The following is a description of a gene set: Any process that activates or increases the frequency, rate or extent of an organismal process, any of the processes pertinent to the function of an organism above the cellular level; includes the integrated processes of tissues and organs. studied in species Homo sapiens Human Gene Set: GOBP_POSITIVE_REGULATION_OF_MULTICELLULAR_ORGANISMAL_PROCESS, and this is the list of marker genes: IFNL1, F3, ETV4, ICOS, BCL7B, IL4, LRP1, CD81, GPR68, BRMS1L, PARP2, GRM5, NAIP, STAP1, ADGRV1, ADNP, BTNL2, CCL24, BICRAL (BICRA like chromatin remodeling complex associated protein), EDN2 (endothelin 2), RGCC (regulator of cell cycle), HES1, CD101, STAU2, LAPTM5, PDPN, PRDM14, CDON, PLA2R1, AGER, PTPRD, NLRP5, HLA-DQB1, BBS4, MIR142, DHX58, MIR34C, TLR8, GSDMD, MIR195, DIO3, AXIN2, LPAR3, MIR1908, RAB7B, EREG, DMRTA2, PEAR1, KITLG, NFAM1, MIR21, FCGR1BP, FABP4, MTDH, ANXA2, SLC6A3, TCF7L2, MIR17, PRKG2, BECN1, DSCAM, JMJD8, ADORA2B, ADAM10, SART1, CHI3L1, FLRT1, HLA-DRB1, NKX2-2, AMOT, PRG2, RUNX1, AQP1, F2RL1, CD244, IRF1, HLA-DRB5, ZC3H12A, CAPRIN1 (cell cycle associated protein 1), AMIGO2, BCL11A, FCGR2A, DDX1, CHRNB4, ZP3, NOX5, GHRH, MIR499A, DPP4, EPHB2, TRAF2, HMGB1, FOXS1, ACE2 (angiotensin converting enzyme 2), AGPAT2, AGPAT1, KSR2, TLR5, RAB2B, CD24, TBK1, FCHO1, LILRA2, ACVR1, ICOSLG, PLA2G4A, BRD9, GLMN, LPIN1, TAC1, IL36B, F2R, IRGM, CHUK, FZD9, CD2, CRH, AMBRA1, EZH2, GATA4 (NCBI Gene Id 2626), CSF2, GRPR, SMARCE1, CADM1, MIR132, GPAM, HAVCR1, DHX37, GPR65, CDK18, PTK2B, SAP30L, PRL, TACR1, NLRP9 (NLR family pyrin domain containing 9), CCDC88B, TNFSF4 (NCBI Gene Id 7292), MAP3K8, PDCD6, HSP90AA1, GPRC5B, POLR3A, CMA1, SERPINE1, IL20RB, QKI (QKI, KH domain containing RNA binding), TRIM56, SPTBN1, RUFY4, WDR62, GAS6, CD320, AXL, NACA, HIF1A, TRIM65, CCBE1, XCL1 (NCBI Gene Id 92337), ATXN1, ADM, P2RX7, AVPR1A, SMARCD2, SOX4, GH1, CCR2, ITGA5, RUNX3, PKDCC, LRRN1, USP22, FOXA2, IL17F, SLITRK6, TNFSF13B, PAXIP1, GP9, SASH3, NTRK3, BRD4, BCL9L, LTBP3, HMCES, MSH2, ZCCHC3, AGTR2, EIF2AK2, LILRB4, MECP2, KDM2B, HEG1, ACTB, RSAD2, MTOR, CACNB1 (NCBI Gene Id 782), MIR204, ZNF365, FGF10, NCOA2, MIR34A, FCGR3A, PANX1, ANO6, GPRASP3, STOML2, EMILIN1, RUNX2, CD7, TGFBR2, TRAF3 (TNF receptor associated factor 3), HMGA2, PRKCZ, PTPN1, ROCK1, ATP8A2, TOX, GATA2, MIR144, HLA-A, SIN3A, MEFV, FGFR1, CCL5, GPSM3, ANGPT2, ING2, LACC1, VTN, SPTA1, PHB1, MIR519D, NPY2R, TBC1D24, CGAS, CYBA, PANX2, HRC, ENPP7 (NCBI Gene Id 339221), AKAP12, CCR1, OTP, GRP, CACNB2, NLRP3, CD1D, IGFBP2, ELL3, TPM1, LILRB1, STAT3, IFNG, XBP1, CSK, GALR1, SVEP1, JAK1, NOG, CD36, LNCPRESS1, IFIH1, CBLN2, GDI1, LGALS3, GSX2, HLA-DRA, PIM1, FCN1, EDNRB, BAD, ASIC2, TGFB3, SLC7A1, TGFB1, ATP6AP2, RBM19, IL20, ADM5, TLR4, SNW1, TSKU, AP3B1, PLXND1, SMAD3, APP, MC1R, AGRN, CD80, FLT3LG, UCP1, RPL13A, TBX21, CIB1, TLR7, MED1, CFAP20, FH, TLR9, GHRHR, NFATC4, PQBP1, CELA1, CHIA, MIR29A, NLGN1, TWIST1, SPACA3, SULF2, CLSTN2, VIL1, RNF135, RBBP7, IL7R, TESC, RGS14, F7, ITGB1, UNC13B, HLA-DQA2, MACROH2A2, TRPV2, KMT5B, IL1RAPL1, PPARGC1B, PER2, FMR1, NLGN2, EMILIN2, MIR208A, TJP1, RPTOR, SMURF2, TIGIT (T cell immunoreceptor with Ig and ITIM domains), DMRT1, DBH, SIRPG, CLCF1, AKT1, TP73, PLXNB2, ELANE, JAG1, NCOA3, DISC1, CCN1, WNT1, ADRB2, CCL1, FAM83A, MIR1-1 (NCBI Gene Id 406904, microRNA 1-1), HMSD, CST7, MFN2, CEACAM20, ECRG4, SOX10, HTR2A, CD86, EPHB3, HLA-DPA1, CYP27B1, PPP2R3C, PRKCQ, VKORC1, POLR3F, CAMK4, MIR199A1, NUMBL, NAP1L1, NPTN, SNX4, ITGAX, ZNF322, PTPRZ1, AVP, KPNA2, BLOC1S3, LRPAP1, BASP1, HMGB2, FYN, NOS3, LGALS8, ADORA2A, RREB1, FN1, LRRTM2, BLOC1S6, MAP3K13, FCER1G, PTGIS, CLEC5A, PDE4B, MPL, LBP, FFAR4, RIMS2, EGR2, NGF, LTF, TMIGD2, CHD7, ANGPTL3, NOS2, ID2, HK1, BMPR1B, PDPK1, TP53BP1, ATP2B1, NMU, ITPKA, AMIGO3, POU4F1, ATP1A1, METRN, NODAL, VAV1, NKX6-2, TBXAS1, ADIPOR2, THBS2, SLITRK2, PKP1, ALOX5, CD226, PRG3, CYP8B1, AVPR2, SOX6, DRD2, MIR145, MIR342, EMC10, SERP1, FOXD1, CTNNBIP1, SEMA4A, OAS3, JAK2, SOX15, TLE6, RELA, LY9, TGFBR1, NLRP2, RB1, CD74, PAFAH1B1, GREM1, NEURL1, SRF (NCBI Gene Id 6722), PDCL3, SEMA4D, NEFL, TMEM64, CLEC4D, TGM2 (NCBI Gene Id 7052), NCMAP, IL33, DNAJA3, HHLA2, SHH, SMARCA2, MIR222, IL12RB1, PLAC8, IL7, CAMK2D, TGFB2, RGS4, IL1A, ZEB2, SIX4, LCK, YAP1, ENG, IFNGR1, RAPGEF3, ERAP1, ACTA2, ARID4A, ADCY10, PTPN6, POLR3B, TWF1, MAPT, MEF2C, CD4, CASP1, RORA, B4GALT5, HSPD1, AGO2, MTM1, CD40LG, ATP2A1, ECM1, FBN2, MAVS, IFI16, FGF8, TNFSF14, OAS2, CLSTN1, HRG, CASR, DEF8, IGHD, ARMCX5-GPRASP2, ING1, MIR33A, GATM, CTNNB1, NOX1, ADAM7, TNR, BDNF, PLXNC1, CX3CR1 (C-X3-C motif chemokine receptor 1), HAVCR2, ZMIZ1, SULF1, INAVA, BTG1 (BTG anti-proliferation factor 1), PRKDC, ASCL1, AP3D1, PMS2, ADAM12, HSPB6, AGGF1, ADRB3 (NCBI Gene Id 94406), FGF2, FZD4, ETS1, STIM1, FGF18, TSHR, BMPER, KAT2A, IL32, KAT5, AKIRIN2, TPPP, RIGI, CD47, CBLN1, TMF1, CTSC, THBD, CCND1, PDGFB, TACR3, IL1R1, PRAP1, MTNR1B, TBX20, IL15RA, IRAK3, SIRPA, VSIR, PRKAB2, FFAR3, SLC1A1, ARID2, ITGB8, TAPT1, PRKCH, MYMK, HSPB1 (NCBI Gene Id 3315), TERT, DECR1, PKM, HSPA1A, RNF112, SIGLEC16, NPPB, SPN, DCT (dopachrome tautomerase), TRPM4, CAMP, P2RY1, ROBO2, CAMK2B, TNFSF9, G3BP1, HYAL1, NTRK1, DHX36, CCL3, CD40, PPP3CA, HLA-DOA, HGF (NCBI Gene Id 317720), CD70, VEGFB, SOX9, TTPA, GRID2, OGT, AKAP6, EGR1 (early growth response 1), FGF21, SERPINF2, MMP8, CPT2, TGFB1I1, IL17RC, ADGRB3, CD14, PYDC1, ACIN1, OSM (oncostatin M), C3AR1, ETV5, BATF, UAP1, FUT1, SLC39A10, SELP, CBFB, TESPA1, ALPL, ZFPM2, STK25, IRF3, ATRAID, MIR214 (NCBI Gene Id 406996), TYK2, GRB10, ADCYAP1, SMARCD3, ALOX12B (arachidonate 12-lipoxygenase, 12R type), SORL1, DICER1, CFL1, SMAD2, PLA2G3, FAAH, TET1, IL34 (interleukin 34), C5AR1, IL6R, GBP5, RAB8B, PCK1, KIT, TENT5A, KPNA6, FXR2, BCL3, CDH5, DBN1, CD160, CD3E, EDN1, PTGER4, IRF5, GNAS, ISLR2, NLRP12, PLPP6, CDKL5, APOA5, IL13, SLITRK5, XIAP, ABL1, CBLB, IRF7, BCL7C, MIR181B1, USF1, NELL1, F12, TNFSF12, BICRA, PF4, DYNC1H1, CDKL3, ARRDC4, IL2RG, RASSF10, HLA-DMA, TIE1, TLR3, CLEC9A, FZD5, CSF1R, LETMD1, S100A13 (NCBI Gene Id 6284, S100 calcium binding protein A13), SMARCD1, PLCG1, TRADD, BMP10, OPRM1, RELN, RIPK2, IL16, LRRTM1, PROK2, TRIM27, CLEC4E, NLRP10, CAPRIN2, DAB2, CUX2, CYBB, USP50, ANGPT4, NR1H4, GSTO1, ADRB1, GADD45G, NEGR1, SHLD1 (NCBI Gene Id 149840), SMO, MRTFB, MSX2, RAB21 (RAB21, member RAS oncogene family), HLA-E, CHODL, CCR3, EFNB2, OXT, MIR125B1, YBX3, ITK, BTN3A1, CARD11, LHX1, MAP6, NPS, ACTL6A, CLNK (cytokine dependent hematopoietic cell linker), VNN1, TBXA2R, TMEM106A, GLI3, EP300, RIMS1 (regulating synaptic membrane exocytosis 1), LPL, RHOA, ARRB2, SPP1, MIR324, HMHB1, CD6, PRDM16 (NCBI Gene Id 647868), GPIHBP1, PLG, MIF (macrophage migration inhibitory factor), NR5A2, NGFR, BMP1, EXOSC6, FABP5, PRLR, HRH1, BST1, SYNDIG1, ORM2, BMP7, CD209, SIRPB1, ALMS1, BRD2, PDE9A, GJA1, TOMM70, SASH1, KL, NKX3-1, HDAC2, ORM1, DDRGK1, CORO1A, CAPN3, POU3F2, APOE, MC4R, LRG1, PPARG, TUSC2, PAX2, NKAP, MAP3K7, GCH1, TBX2, DLG5, JUND, MAPK14, LIPG, IDO1, STAT6, IRF4, LAMTOR5, MIRLET7G (microRNA let-7g), MIR30B, IL26, MUSTN1, MIR1224, ZFPM1, CARD9, LGALS1, IL1RL1 (interleukin 1 receptor like 1), MIR657, ENO1, PLXNB1, WNT4, MME, SPX, CYP19A1, MMP14, RXRA (retinoid X receptor alpha), ANXA1, MAN2A1, NPY, SHOX2, OSR1, HTR2B, UNC93B1, CCNB1, RFX3, G0S2 (G0/G1 switch 2), ADRA2A, CEBPA, SERPINB7, CD38, ALOX15B, DDT, PRDX2, GLI1, NCOA1, TMBIM1, LRP8, EBI3 (Epstein-Barr virus induced 3), VAMP8, OAS1, ADRA1D, LOXL2, TNFRSF1B, CXCL8, SLITRK4, ACTL6B, RTN4, PLAT, STMP1, INSL5, ANGPTL4, ZFP36L1, DHX33, RIPK1, HIPK1, EFNB1, ATP1A2, WT1, CACNA1C, ATAD5, APOC2 (NCBI Gene Id 344), CD276, IL23R, IL2, STAT5A, MMRN2, OPA1, MMP12, TLR2, EIF2AK3, SLITRK1, HLA-DQB2, PAX6, DAG1, LEP, GPR3, ERBB3, PDE4D, CLIC3, DEFA5, SLIT2, FCGR2B, ZC3HAV1, C1QTNF1, MAP2K1, MYF5, AFAP1L2, RBPJ, NPR1, CDK1, LURAP1, BTN3A2, ZNF488, SFXN5, ANKRD27, ELOVL3, VEGFA, SPI1, MYDGF, JCAD, RETN, SLAMF6, FXR1, APLNR, DDX21, MAPKAPK2, PRKCA, GP1BB, ESRRB, NTSR1, FST, SMARCC1, LMOD3 (NCBI Gene Id 56203, leiomodin 3), HLX, CCL19, MIR15B, SPHK1, HLA-DMB, SAA1, TNFRSF8, HLA-DRB3, CD27, SAP30, PRMT5, LRRN3, NIPBL, BIN1, SCN3B, CLU, P2RY2, SLC27A1, BMP6, TGFBR3, BMPR2, TACR2, PIK3R1, MIR143, NR5A1, RAD21, ZBTB20, NCKAP1L, MESP1, PEMT, TIAM2, DLL1 (delta like canonical Notch ligand 1), SCD, MIR378A (microRNA 378a), B2M, RAMP2, KLHL25, VASH2, MIR126, IL10, CLEC12A, FERMT1, ZBTB46 (zinc finger and BTB domain containing 46), PIK3R6, OLIG2, LUM, RAET1G, PARD3, MYD88, MAD2L2, OLFM1, MIR128-1, CHRNB2, PTPRC, NPAS2, MIR206, OSR2, WNT2B, CACNA2D2, LCN2, IGF1, SHLD3, REST, ZNF703, NMBR, BRD7, LEF1, FRMD8, PRKD2, AGRP, SPTBN4, MIR27B, SERPINE2, RAB1A, FOXC2, RND2, MIR548C, ZBED2, OVOL2, APPL2, ADGRB2, MIR20A, GCNT2, E2F1, WNT5A, CXCL17, SLC7A5, GPER1, ITPKB (inositol-trisphosphate 3-kinase B), DHX9, AKT3, IL4R, TTBK1, INHBB, ROBO1, BMPR1A, SHLD2 (NCBI Gene Id 54537), WNT10B, XRCC2, MIR17HG, SERPINB3, TM4SF19, ST3GAL4, LYN, MIR451A, HAP1, ACSL1, ST8SIA2, TIRAP, GATA6 (GATA binding protein 6), DDR2 (NCBI Gene Id 4921), ESRRG, TYROBP, CCL21, SMARCC2, NLRP1, IHH, MIR590, AVPR1B, MIR16-1, CARD8, CDH4, PLCB1, NTRK2, PRKCB, FADD, MIR182, VSTM5, MYOCD, PIK3CG, ZP4, ALX1, GFAP, PTK2, SOX5, CRB2, PAX8, TMPRSS12, CLSTN3, SRPX2, CREB1, MAP1B, DEFB131A, NFATC2 (NCBI Gene Id 4773), NRDC, ARFGEF2, PTPN22, SCT, SIX1, FOXG1, TRAF3IP3, IL5, SS18L1, BBS2, NRP1, SRRT, MYB, KLRK1, DKK1, HSPA1B, KIR2DL4, PAEP, ATG5, TNFRSF12A, RGS2, MLH1 (NCBI Gene Id 4292), TP63, TRIM32, MACROH2A1 (NCBI Gene Id 9555), ACVR2A, MEF2A, LGALS9, ARID1A, S100B (S100 calcium binding protein B), PYCARD, EZR (ezrin), WNT2, AIF1, ATF4, BCL10, BMP2 (NCBI Gene Id 650), PHF10 (PHD finger protein 10), SAP130, GPR183, KLRF2, MAPK9, PLCG2, BCL6, SFRP2, SMTNL1, VPS35, CARTPT, TNFRSF11A, IL12A, FBXO38 (F-box protein 38), MIR509-1, SPINT1, SERPINF1, HYAL2, UTP25, TRPC3, CDKN1A, HDAC3, MIR31, ABAT, INHA, GHR, ZBED3, OXTR, MYRF, IL21, C1QTNF4, GATA5, ABL2, FOXJ1, VDR, POU2F2, TENM4, ANXA3, ADIPOQ, PTGS2, HTN1, BRMS1, STAT1, MIR125A, INPP5D, IQSEC2, IL9, WNT3, NIN, ELOVL6, TFRC, ARID1B, CNOT3 (NCBI Gene Id 9756), HRH2, ZNF580, PPIB, APOH, CALCA, EPX, BMI1, VAMP7, SMAD7, CLECL1P, FOXP3, PLAG1, TRIB1, GPLD1, C3, EFNA5, FES, IL12RB2, APPL1, MIR19A, EFNB3, MAGED1, VEGFC, GPM6B, YBX2, TEAD4, BAIAP2, TICAM1, MIR19B1, TIAM1, EPHB1, CCL2, IL4I1, SOX12, DOCK8, HSF1, IL2RA, KCNQ1, SMAD4, KLHL22, HLA-F, CD83, DDAH1, AR, ISG15, HLA-DPB1, WNT3A, FOXL2, ITGB3, BCL2, HIPK2, LINGO2, KLRC4-KLRK1, RFTN1, PLA2G1B, ARX, PPARGC1A, YWHAG, AIM2, TMED10, DENND1B, MBP, POU4F2, TRPV4, HAX1, CLEC7A, KMT5C, PARP6, PLAU, ARRB1, ACACB, ADD3, PLEKHM1, POU5F1, ZAP70, HILPDA, MIR199B, MIR675 (microRNA 675), RPS19, NPNT, FLOT2, PLXNB3, FRS2, RASAL3, FGA, ACHE, CASP8, HDAC6, MFAP2, FGF9, SGIP1, MIR34B, EGR3, CD5, ADM2, LIMK1, IKBKE, KDM3A, APELA, SNAI1, LILRA5, EVI2B, GHSR, APOA2, SRY, WARS2, INHBA, RBBP4, ERBB4 (erb-b2 receptor tyrosine kinase 4), CCL11, DEFB124, CACNG1, TNF, BSCL2, C1QBP, THY1, KLF10, FLT1, TNN, GAPDH (NCBI Gene Id 2597), HOXA11, UFL1 (NCBI Gene Id 23376), IL6ST, CXCL12, PIK3CD, CUL7, CAV1, PANX3, NRG1, TNFSF13, ITGB2, AGT, FCRL3, ANGPT1, PTPN11, GAL, IL1RAP, CX3CL1, SETD2, HCLS1, IL12B, NFKBIZ, EEIG1, GLI2, SMARCB1, PELI1, SLAMF1, EEF2K, IL18, MIR302A, IRS2, ITCH, TNFRSF4, ARHGEF2, NR1H2, CD58, ADRA1A, MIR99B, DDIT3, PTH, CD55, PTH2R, BMP4, TNFRSF14, BRCA1, IL1RL2, TRAF6, ID4, GDF2, TLR6, BAMBI, TRPC5, FOXP1, ATF2, CACNA1S, SEMA5A, TAC4, MCOLN2, CLCN2, TSLP, OTX2, STOX1, CEBPB, TSPO, IL17RB, UCP2, C5, ACVRL1, GAB1, ADAM8, VTCN1, OMA1, LILRB2, CD274, PAK1, NR2C2 (NCBI Gene Id 7182), TREM2, PIBF1, INPP5K, LRRK2, EBF2, MAPK11, FOXC1, PEX5, RHOH, SIRT1, HK2, CCR7, NOTCH2 (NCBI Gene Id 55574), KDR, SINHCAF, TOB2, ITGA2, CHRM3, IST1, ZNF335, CRABP2, NKX6-1, FCGR2C, SYDE1 (NCBI Gene Id 85360), SPRR5, GBA1, LRTM2, PLS1, GP5, SP1, RPS6KA1, ACVR1B, BCL7A, SEMA7A, CUX1 (cut like homeobox 1), STK11, NECTIN2, HLA-G, LBH, SRC, SMARCA4, NMB, ATPSCKMT, DUSP10, KHDC3L, SPON2, SHANK3, LGR4, NKX2-5, RPS3, APLN, CCN3, KLF4, NUMB, GATA3, LRRC4B, ADIPOR1, TNXB, GDNF, FFAR2, ZNF516, CEBPG, ABCC8, THBS1, SCX, FOXO3, SMAD1, PRKD1, MACF1, SCAMP5, FGR, MIR486-1, CSF1, PARK7, NOTCH1, MDK, GHRL, GPR21, EGF, MTPN, LPCAT3, NUMA1, HLA-DQA1, IL17B, HAND2, KARS1, VAV3, SHTN1, SCIMP, CXCR4 (NCBI Gene Id 93405), TANK, MKKS, GLIPR2, STAT5B, CR1, GRIA1, PRKAR1B (NCBI Gene Id 645590), IL27, RAG1, MAP2K2, RRAS, NOD2, WNT7A, RXFP4, ABCA1, GARIN5A, LIF, KDM5B, NFE2L2, L1CAM, RIF1, CHGA, JUP, FOXN1, ADAM17, MIR379, ARNT, GJA5, RIOK3, POLR3G, HNRNPK, THRA, SPRY1, FOS, SECTM1, FLRT2, TXK (TXK tyrosine kinase), ACTN3, KRT17, PCID2, MIR149, WNT11 (Wnt family member 11), TNIP2, MIR130A, PRKCI, FAM20C (NCBI Gene Id 56975), EPHA1, SS18, MYC, MAG, HADH, LIG4 (DNA ligase 4), NEDD9, ZBTB7B, ADGRB1, SOCS5, RET, PBRM1, SLC22A5, PENK, ZFYVE27, VCAM1, EMP2, RAG2 (NCBI Gene Id 5897), SHB, GOLGA4 (NCBI Gene Id 2803), RHEB, HSPH1, MAPK13, MALT1, TAFA3, LRRTM3, SYK, WWTR1, LY96, DDX3X, FZD3, CXCR3, RACK1, SLC9A1, NCK1, NLGN3 (neuroligin 3), BSG, COL1A1, GP1BA, KDM6B, MEGF8, ACADL, SLC8A1, ARID5A, PNP, MIR30A, IL23A, FERMT2, RASGRP1, FLOT1, STRA6, CYLD, RUFY3, ARID4B (NCBI Gene Id 88087), SH3KBP1, NPPA, CRTAM, CITED2, RBM47, TNFRSF13C, MYF6, TFAP2A, CYP1B1 (NCBI Gene Id 1545), PROX1, SOX11, SELENOK, FBXW8, SOD1, ACVR2B, SKIL, MYOG, EPHA4, C1QTNF3, SLN, MIR210, NR2E1, SLITRK3, IQGAP3, FLNA, GDF6, NSD2, AMIGO1 (NCBI Gene Id 57463), FGB, IL18R1, PTN, ZNF219, WNK1, NFKBID, SOCS1, HCRT, LRP2, NME2, CRLF2, FSHB, GRN, HDAC1, ISL1, CD46, YES1, MIRLET7B, TPBG, NTN1, LEPR, SLC11A1, PLEK, TCF3, HLA-DOB, IL15, IRF8, GDF5, IGF2, PRKCE, XRCC6, IL36A, PSEN1, ANAPC2, BRAF, IL27RA, NOD1, RHOB, CD200, TEK, ZNF304, IL17A, EHMT1, MIR33B, ENPP4, PAK4, FLRT3, RYR2 (ryanodine receptor 2), RARA, FGF1, NCK2, OCSTAMP, FGG, DSG2, UCN, AZU1, CMKLR1 (NCBI Gene Id 1240), PHOX2B, TBX5, BTK (Bruton tyrosine kinase), SMURF1, HOXB7, RLN2, AIRE, IL17D, POR, GSK3A, TLR1, SETD4, CHRNA7, APC, ABCA7, EPAS1, PTPRJ, SCRIB (NCBI Gene Id 23513, scribble planar cell polarity protein), TMEM119, TWF2 (NCBI Gene Id 11344), POU2AF1, MIR221, IRAK1, SLC9B2, HCAR2, ROCK2, NINJ1, IL1B, HRAS, FLT4, SMOC2 (NCBI Gene Id 64094), SOX8, TRIM16, DCSTAMP, DIO2, STING1, OBSL1 (obscurin like cytoskeletal adaptor 1), DHPS, SUDS3, ADRA2B, IGF1R, CTTN, NRXN1, LINGO4, CD34, TNFSF11, PRKAB1, FGFR2, PARP1, EXOSC3, EDN3, LDLRAP1, SPHK2, TRAK1 (NCBI Gene Id 22906), HEY2, BTN2A2, CLEC6A, PLAAT4, POLR3C, SLC20A2, OPRK1, TRIM6, ZBTB16, SPEN, ADA, PDGFC, FCGR1A, DPF2, S100A1, KRAS, MSX1, PDCD1LG2, RXRB, XRCC5, ASPM, WASF3, ZBTB1, MIR133A1, KDM1A, TRIM15, TICAM2, HOXC11, PPP1CC, HPSE, SDCBP, NLRC4, INS, SOX13, SIRT6, ATP2A2, CYRIB, F2, MIR92A1, MYOD1, NR4A3, PRKAA1, RNF10, HLA-DRB4, TRPM8, LTA, IL17RA, POLR3D, SLC30A1, HMOX1, LRRC24, PTGER3, LTB (lymphotoxin beta), EPO, POSTN, CD28, IL6